The following is a description of a gene set: Avascular necrosis A disease where there is cellular death (necrosis) of bone components due to interruption of the blood supply. Human Gene Set: HP_AVASCULAR_NECROSIS studied in species Homo sapiens, and this is the list of marker genes: SLC2A10, ERAP1, SIL1, HPGD, COL1A2, DVL1, TONSL, NHP2, TINF2, SKIC3, SH3PXD2B (NCBI Gene Id 57517), WNT5A, TERT, CCR1, KRAS, CLCN7 (chloride voltage-gated channel 7), SMAD2, COL9A2, IL12A, TRPS1, FZD2, ATRX, UBAC2, SRCAP, EP300, ZMPSTE24, LMX1B, MATN3, PTPN11, ORC1, UNC45A, MMP13, SCARB2, TYMS, MEFV, BRAF, CREBBP, ACAN, NPM1, TP53, FN1, ACTG1, COL1A1, KLRC4, MAN2B1, TRPV4, LMNA, PARN, CTC1, C4A, WRAP53 (WD repeat containing antisense to TP53), RAD21, USP48, TLR4, SLCO2A1, COMP, USB1, ACTB, RTEL1, IL23R, ARSB, SMAD3, NR3C1, IL6ST, IL12A-AS1, CDH23, RAB3GAP2, HBB, DVL3, GBA1, NEK9 (NIMA related kinase 9), USP8, IL10, ATP7A, COL2A1, ADAMTS2, DYRK1A, ELP1, ADAMTSL2, TREX1, EXT1, HLA-B, PHF6, TERC, DKC1, NTRK1, UFSP2 (UFM1 specific peptidase 2), FAS, IFNGR1, STAT4, FGFR1, NOP10